The following is a description of a gene set: Neighborhood of PCAF studied in species Homo sapiens Neighborhood of PCAF p300/CBP-associated factor in the GNF2 expression compendium Human Gene Set: GNF2_PCAF, and this is the list of marker genes: ERMAP, SELENBP1, AHSP, MAP2K3, RHAG, MARCHF8 (membrane associated ring-CH-type finger 8), ANK1, PPOX, KAT2B, FBXO9 (F-box protein 9), HBQ1, FECH (NCBI Gene Id 2235), TSPAN5, GYPB, MARK3, XPO7, EIF2AK1, HMBS, SPTB, EPB42, CLIC2, RHD, CROCCP2, LPIN2, CA2, TSPO2, ALAD, RHCE, GYPA, EIF1AY, GYPE, SLC4A1, ALAS2, SPTA1, TRAK2, TRIM10